The following is a description of a gene set: species: Mus musculus Reactome Pathway: RNA Polymerase III Transcription This event has been computationally inferred from an event that has been demonstrated in another species.<p>The inference is based on the homology mapping from PANTHER. Briefly, reactions for which all involved PhysicalEntities (in input, output and catalyst) have a mapped orthologue/paralogue (for complexes at least 75% of components must have a mapping) are inferred to the other species. part of: Gene expression (Transcription) electronically inferred by orthology from the curated human pathway, and this is the list of marker genes: Snapc1, Gtf3c2 (general transcription factor IIIC, polypeptide 2, beta), Gtf3c5, Polr3d, Snapc3, Polr3c (polymerase (RNA) III (DNA directed) polypeptide C), Tbp, Crcp, Polr3e, Gtf3c1, Polr2l (polymerase (RNA) II (DNA directed) polypeptide L), Gtf3c3, Polr2k, Polr3h, Polr2f, Gtf3c6, Polr3g, Polr2e, Polr1c, Pou2f1, Bdp1